Given this list of marker genes Ctss, Capns2, Cma1, Col2a1, Cast, Col4a2, Mmp11, Col10a1, Capn7, Mmp13, Spp1, Timp1, Capn1, Adamts4, Col12a1, Mmp17, Mmp15, Col13a1, Klk7, Col6a6, Mmp8, Col6a5, Col18a1, Cdh1, Capn13, Acan (aggrecan), Dcn, Elane, Mmp14, Mmp12, Plg, Mmp2, Mmp10, Bsg, Ctsg, Capn5, Col19a1, Mmp25, Spock3, Col8a2, Htra1, Prss2, Col4a6, Mmp3, Capn8, Capn15, Mmp7, Adam15, Tmprss6, Capn9, Col6a1, Phykpl, Scube3, Col7a1, Mmp19, A2m, Prss3, Col4a5, Col11a2, Capn6, Ctsd (cathepsin D), Klkb1, Col15a1, Col8a1, Mmp20, Adam8, Col5a3, Optc, Col25a1, Try10, Scube1, here is a description of the gene set: part of: Extracellular matrix organization This event has been computationally inferred from an event that has been demonstrated in another species.<p>The inference is based on the homology mapping from PANTHER. Briefly, reactions for which all involved PhysicalEntities (in input, output and catalyst) have a mapped orthologue/paralogue (for complexes at least 75% of components must have a mapping) are inferred to the other species. Reactome Pathway: Degradation of the extracellular matrix electronically inferred by orthology from the curated human pathway studied in species Mus musculus